The following is a description of a gene set: Human Gene Set: GSE12845_PRE_GC_VS_DARKZONE_GC_TONSIL_BCELL_DN from publication Longo NS, Lugar PL, Yavuz S, Zhang W, Krijger PH, Russ DE, Jima DD, Dave SS, Grammer AC, Lipsky PE (PMID 19023113) Genes down-regulated in comparison of pre-germinal center B cells versus dark zone germinal center B cells. B cells from human tonsil and blood were sorted using flow cytometry. The human samples were processed immediately ex-vivo using markers for known B cell subsets. species: Homo sapiens, and this is the list of marker genes: RBX1, PMPCA, HIKESHI, RRP8, LARP7, PTPN18, E2F6, UGP2, DLAT, RCOR3, SGPP1, URI1, MRPL15, MICU2, STK17A, COQ4, UBR5, PEX3, MON1B, SEC13, SEC62, RALBP1, RETREG2, SNF8, UBE4A, GNRH1, KIF2A, ZMAT5, NNT, ACTR2, PDHX, UBE2J1, EIF2D, CAD, ATP5F1B, TBC1D1, NKIRAS2, IFFO1, CDK7, PEF1, BTAF1, DDX1, ALDH2, SYBU, COMMD4, DCTN3, RBM39, C5AR2, BBS1, BLM, GLS, DDX41, PDK2, QPCT, GLRX5, KIFAP3, DNAJB6, UCHL1, TRMT5 (NCBI Gene Id 57570), NUDT1, PCDHA3, MED20, NF1 (NCBI Gene Id 646021), CD3D, TRAFD1, BCL11B, FBXL7, SCMH1, IGHA1, DENND4A, NOL9, MEN1, COPS7A (COP9 signalosome subunit 7A), GPS2, SARS1, OSBPL11, PNN, NGRN, COA1, BLOC1S1, TMEM230, HTR3A, TRAK1, LARP4, STAT5B, ERP44, ARPC1A (NCBI Gene Id 10552), NDUFAF1, USE1, RERE, KLC1, CDC45, TUBGCP4, E2F5, NAXD (NCBI Gene Id 95526), DAP, C1GALT1C1, UBXN1, ANP32B (NCBI Gene Id 138551), WEE1, RPL36A, SNTA1, TANK, ATP5MG, MAP3K7CL, C19orf53, ATP5MJ, EMG1, PLK4, PDCD6IP, TMEM248, TIAM1, SPATS2, CLINT1, POLR2J, CLPX, TIMM10B, IMP4, HERC2, RNF103, ABCA11P, CLTC, CDK19, EIF4E, UQCR10, VOPP1, RFC1, BACH2, MOK, STXBP6, COLEC11, MME, FAU, BCL2L2, FAM32A, ST13, C2orf49, FBXL12, EMC6, ALOX5AP, COX10, RER1, REEP5, NAA38, BAZ1B, CORO1B, RNFT2, NENF, BCL7A, CZIB, PSIP1, PSPC1, TBC1D12, SNU13, WAPL, CDC6, CTPS2 (NCBI Gene Id 95807), NUS1P3, GTF2H1, VAMP2, UBE2G1, ILRUN, ARFGEF1, RBM6, DCTN4, LCK, HDAC6, FAS, STX7, ABCC1, MRPS33, SEL1L3, ABT1, AMZ2, COX6B1, GUK1, LRCH3, YIPF1, YY2, GSTP1, EID1, RAD21, POLR1HASP, SYPL1, RHOQ, MTMR12, SUSD6, XCL1 (X-C motif chemokine ligand 1), POLG2, PLAG1, USP7, ZNF35, CYREN, HLTF, VDAC1, IFT57, CD27, TOR1A, NEIL1